Given this list of marker genes RORA, UGGT2, PRICKLE2, LRATD2, TNS1, RAB29 (RAB29, member RAS oncogene family), ABCC4, SRP19, INSR (NCBI Gene Id 3643), ZNF287, TNRC6B, SDK1, FBXW11, CLCN3, RPL36A-HNRNPH2, FGF13, SMARCD1, SLC9A7, RFX7 (regulatory factor X7), MANEAL, TRIM9, C6orf136, CLMP, TMEM267, MAP3K9, TIA1, SMCR8 (SMCR8-C9orf72 complex subunit), NIPBL, MCM6, CCR5, SNED1, TAOK1, PPBP, CNDP2, AFTPH, EEF1A1, ZC3H12B, XG, NUDT15, PARM1 (prostate androgen-regulated mucin-like protein 1), TNFRSF19, POU2F1, HTR5A, MPDZ, GRAMD1B, NFATC2, XYLT1, LARP1, ENSG00000255537, SLC16A4, ERBB4, TMEM178B, DUSP18, NMD3, MMP2, CA8, ZNF366, HAO1, CENPBD1P, RAPGEF4, SV2B, AAK1, PAX2, CRACDL, ZSWIM6, UBR3, CHRM2, STAT5B, COG3, NR6A1, SH3TC2, CREB5, TTC7B, RASSF5, NMT1, NFASC, PKNOX2, CENPA, CD300E, KDM3B, RAD54L2, PTGER4, ATL3, C1orf115, ERICH5, FABP7, GFRA1 (NCBI Gene Id 2674), XKR7, RIDA, NAV1, TMPRSS15, NEUROG2, FXYD3, KCNB1, AGAP1, ANKRD13C, CACNA1E, LMLN (NCBI Gene Id 89782), TRAF3, SOX4, RIMKLB, HOXA10, VAPB (NCBI Gene Id 9217), ANKRD37, GAREM1, SSTR3, PRDM16, MON2, ARMC2, SORCS1, TBK1, here is a description of the gene set: species: Homo sapiens from publication Chen Y, Wang X (PMID 31504780) Genes predicted to be targets of miRBase v22 microRNA hsa-miR-320a-5p in miRDB v6.0 with MirTarget v4 prediction scores > 80 (high confidence targets). Human Gene Set: MIR320A_5P